The following is a description of a gene set: Any process that modulates the frequency, rate or extent of the directed movement of organic acids into, out of or within a cell, or between cells, by means of some agent such as a transporter or pore. species: Homo sapiens Human Gene Set: GOBP_REGULATION_OF_ORGANIC_ACID_TRANSPORT, and this is the list of marker genes: ITGB1, THBS1, ABAT, FABP3, ACSL5, SYK, NPY5R, CYP4F2, RGS2, PSEN1, ARL6IP5, SLC38A2, AKT2, GABBR1, MIF, STXBP1, SLC17A8, REPIN1 (NCBI Gene Id 96712), PLA2G4A, SLC38A3, ABCB11, SNCA, ATP1A2, NTSR1, PPARA, EPRS1, RGS4, GRM2, TNFSF11, RAB3GAP1, KMO, DTNBP1, PLA2R1, TRH, P2RX7, PLA2G3, PTGES, EDN1, TNF, ACE2, CLTRN (collectrin, amino acid transport regulator), AKT1, MIR33A, CYP4A11, GRM7, ERFE, ACSL4, P2RX4, IRS2 (NCBI Gene Id 90066), SLC12A2, ARL6IP1, CES1, FIS1, ADORA2A, PER2, SLC43A2, LEP, CLDN2, AVP, SYT4, SLC43A1, AVPR1A (arginine vasopressin receptor 1A), OXT, ADORA1, PLA2G10, SEPTIN2, AVPR1B, PRKG1, ACSL1 (acyl-CoA synthetase long chain family member 1), TNFRSF11A, IL1B, SLC7A5